Given this list of marker genes MEF2C, KAT2B, ITGA2, FGF23, PTH, HDAC3, CITED1, SOST, PHEX, PRKACA, GNAS, SLC34A1, HDAC6, WNT10B, FOS, here is a description of the gene set: Human Gene Set: GOBP_RESPONSE_TO_PARATHYROID_HORMONE species: Homo sapiens Any process that results in a change in state or activity of a cell or an organism (in terms of movement, secretion, enzyme production, gene expression, etc.) as a result of a parathyroid hormone stimulus.